Given this list of marker genes PDE8B, CAMK2N2, AHNAK2, LPIN2, CTDSP2, STARD5, FAM107B (family with sequence similarity 107 member B), PRIMPOL, SEC22C, TMEM38B, SMPD1, GRB2, BNIP3L, TMEM150C, UBALD2, CNPY4, NICN1, RASA3, FGD3, APOBEC1 (apolipoprotein B mRNA editing enzyme catalytic subunit 1), NAXE, PHLPP1, TBC1D9, POLR2G (NCBI Gene Id 5436), COMT, RCBTB2, BCL2L11, E2F7, FKBPL, OSBPL11, LRP1 (LDL receptor related protein 1), ABCD2, BUB1B, DTNBP1, PLPP3, OPHN1, IRF2BPL, CDKN2C, DYNLT2B, STAG2, KIF21B, BUB1, RTN3, DNAH2, MPPE1, PARP8, MSRB2, SYNPO2, CACFD1, NDUFA6, POLR2A, SMPDL3A, HPSE, TEF, ARHGAP9, PPM1K, PDP1, ITGB8, MIS18A, CCR2, MSH6, ZMAT1, TRAFD1, ABHD4, ARHGAP15, SNX33, OIT3, RAPH1, RETREG2, ASCC1, NUDT18, TTC12, KLC4, CDKAL1, CSRP1, NOTCH2, PDE7A, DNAJC12, SCPEP1, DARS2, RNASET2, CKLF, NME7, LANCL1, HDAC5, L1CAM, PSEN1, RFWD3, RIT1, PARP2, B4GALT6, PPIP5K1, EVI2B, ABCC4, MAP3K9, TNKS, SGSH, HTATIP2, NDNF, PARN, THBD, MSL3, WDR81, HLTF, UVSSA, ZNF503, WASF2, RFXAP, FAM117B, DHX32, CCNG2, IL16, TMEM106C, ACSS1, OGA, FOS, PLIN2, MPP1, POLD3 (DNA polymerase delta 3, accessory subunit), BEX1, NR3C1, SLC30A5, CUTC (NCBI Gene Id 51076), MAMDC2, MMP8, MZT2B, HFE, ADIPOR1, GRAMD2B, KYAT1, FIG4, SERPINB6, ARL5A, RSAD2, GPR162, METRNL, GSN, TST, NFIC, CLIP1, SDF2, CCDC186, PCYOX1, ECH1, ZFHX3, XPA, MCEE (methylmalonyl-CoA epimerase), AKIP1, USF1, HMGCL, EXOC6, ISCU, ARL6IP1, LPXN, CSTF2T, SEMA4D, EPS15, LYL1 (NCBI Gene Id 4066), ZNF467, USE1, SLC16A10, ITSN1, RGS10 (NCBI Gene Id 6001), DEPTOR, DAG1, ACOT13 (NCBI Gene Id 55856), NKAP (NFKB activating protein), CCDC90B, MEF2D, BAZ2B (bromodomain adjacent to zinc finger domain 2B), DOCK2, B3GNT8, HDAC9, TMEM106B, EEF1A2, ACP6, HADHB, SLC44A1, PIK3AP1, DEPDC5, SLC30A1 (NCBI Gene Id 7779), CDC42EP3, FTO, NAV2, RAD50, CYP3A4, ARHGAP17, CYFIP2, CNOT8, EIF2D, VSIG10, MAPK14, TEDC2, ZBTB11-AS1, TIGD2, PANK1, APPL2, STAT4, TBC1D10C, CD300A, here is a description of the gene set: Gene expression from WT and NFAT5 KO primary macrophage cultures. Human Gene Set: GSE26343_UNSTIM_VS_LPS_STIM_MACROPHAGE_DN Genes down-regulated in bone marrow-derived macrophages: control versus stimulated with LPS. from publication Buxadé M, Lunazzi G, Minguillón J, Iborra S, Berga-Bolaños R, Del Val M, Aramburu J, López-Rodríguez C (PMID 22312110) species: Homo sapiens